The following is a description of a gene set: Mouse Gene Set: GOBP_RESPONSE_TO_EPIDERMAL_GROWTH_FACTOR Any process that results in a change in state or activity of a cell or an organism (in terms of movement, secretion, enzyme production, gene expression, etc.) as a result of an epidermal growth factor stimulus. species: Mus musculus, and this is the list of marker genes: Akt1, Mapk1, Tpr, Foxc1, Fos, Gstp1, Pde8a, Cad, Egfr, Vil1, Dusp3, Knstrn, Snai2, Zpr1 (ZPR1 zinc finger), Sox9, Zfp36, Zfp36l1, Inpp5k, Iqgap1, Dusp22, Erbb4, Spg21, Syap1, Snx6, Dab2, Stat5b, Becn1, Baiap2, Med1, Garem1, Grk2, Ptpn12, Bag4, Arpc2, Dab2ip, Ppp1r9b, Pdpk1, Ncl, Git1, Ptpn11, Plcg1, Mapk3, Ireb2, Rasa1, Zfp36l2, Erbb2, Col1a1, Eef1a1, Bloc1s6, Cfl1 (cofilin 1, non-muscle), Mars1, Ascl1, Mcm7